The following is a description of a gene set: studied in species Homo sapiens from publication Schaefer CF, Anthony K, Krupa S, Buchoff J, Day M, Hannay T, Buetow KH (PMID 18832364) VEGF and VEGFR signaling network Human Gene Set: PID_VEGF_VEGFR_PATHWAY, and this is the list of marker genes: VEGFA (vascular endothelial growth factor A), NRP2, NRP1, KDR (kinase insert domain receptor), VEGFB, VEGFD, FLT1, FLT4, VEGFC, PGF